Given this list of marker genes COG2, DYNC1LI1, ARF1, DCTN6, TMED10, SEC22C, TUBB8 (NCBI Gene Id 347688), SEC31A, COPG1, GRIA1, COPZ2, TRAPPC6A, DYNC1I2, ARFGAP2, SPTBN1, MIA3, LMAN2L, CAPZA2, TRAPPC3, DYNLL2, DCTN3, TRAPPC10, TUBA4B, ANKRD28, ACTR1A, TMED7, CTSZ, DYNC1I1, NAPA, CNIH1, MIA2, COG6, SERPINA1, MCFD2, TRAPPC1, DCTN1, TUBB6, ANK2, LMAN1L, COG4, TUBB1, SEC16A, CAPZA3, DYNC1LI2, TUBA3D, CNIH2, LMAN2, CD59, SAR1B, NAPB, PPP6C, COG1, COG5, TMEM115, ANK1 (ankyrin 1), TRAPPC4, TMED9, TUBA1A, SEC31B, TUBA1C (NCBI Gene Id 84790), ARFGAP1, TUBA1B, COPZ1, TFG, RAB1B, SEC16B, TUBAL3, DYNC1H1, COL7A1, TRAPPC9, COG7, YKT6, DYNLL1, TRAPPC2L, PPP6R3, TMED2, F5, TBC1D20, GORASP1, TRAPPC6B, COPA, DCTN5, SPTB, SPTBN5, SEC24B, TRAPPC2, CD55, ACTR10, RAB1A, ARF5 (NCBI Gene Id 381), COPG2, KDELR3, KDELR2, CAPZA1, TUBB4B, TUBB2B, ARCN1, TUBB4A, SPTA1, DCTN4, SCFD1, SEC23A, KDELR1 (KDEL endoplasmic reticulum protein retention receptor 1), ARF4, SPTBN2, NAPG, SPTAN1, SEC24A, SEC24C, NSF, TUBB2A, USO1, STX17, LMAN1, TUBB3, SEC13, BET1L, CNIH3, ANK3, TUBA3E, CAPZB, STX5, TUBA3C, ARF3 (NCBI Gene Id 377), AREG, TUBA4A, COG3 (component of oligomeric golgi complex 3), COG8, SEC23IP, BET1, TUBA8, F8 (coagulation factor VIII), TMED3, CTSC, FOLR1, DCTN2, TRAPPC5, TUBB8B, PREB, ARFGAP3, COPB2, SEC22B, SPTBN4, GOSR1, COPE, GOLGA2, GOSR2, GBF1, GOLGB1, TGFA, PPP6R1, COPB1, SEC22A, CSNK1D, INS, SEC24D (SEC24 homolog D, COPII coat complex component), here is a description of the gene set: Reactome Pathway: ER to Golgi Anterograde Transport studied in species Homo sapiens part of: Membrane Trafficking; Transport to the Golgi and subsequent modification Secretory cargo destined to be secreted or to arrive at the plasma membrane (PM) leaves the ER via distinct exit sites. This cargo is destined for the Golgi apparatus for further processing. About 25% of the proteome may be exported from the ER in human cells. This cargo is recognized and concentrated into COPII vesicles, which range in size from 60-90 nm, and move cargo from the ER to the ERGIC. Soluble cargo in the ER lumen is concentrated into COPII vesicles through interaction with a receptor with the receptor subsequently recycled to the ER in COPI vesicles through retrograde traffic. The ERGIC (ER-to-Golgi intermediate compartment, also known as vesicular-tubular clusters, VTCs) is a stable, biochemically distinct compartment located adjacent to ER exit sites. Retrograde traffic makes use of microtubule-directed COPI-coated vesicles, carrying ER proteins and membrane back to the ER.